Given this list of marker genes COQ4, BRCC3, GNB2, ADA2, MYLK, LOX, HTRA1, FBN1, THSD4, TGFBR1, COLGALT1, GUCY1A1, TGFB3, SMARCAL1, MAT2A, TGFB2, ACVRL1, SMAD4, HEY2, PRKG1, ELN, ENG, COL4A1, SMAD3, NPPA, TBK1, SON, PIK3C2A, SLC2A10, SCN5A, TGFBR2, FOXE3, ACTA2, NAGA, MFAP5, HBB (NCBI Gene Id 3043), JAK2, SMAD2, MYH11 (myosin heavy chain 11), POLG, NOTCH3, here is a description of the gene set: Human Gene Set: HP_CEREBRAL_INFARCT studied in species Homo sapiens Cerebral infarct A necrotic lesion in the cerebrum resulting from a sudden insufficiency of arterial or venous blood supply due to emboli, thrombi or mechanical factors.